Given this list of marker genes Mapkapk3, Kras, Grb2, Mapkapk2, Shc1, Sos1, Mapk11, Mapk14, Hras, Shc2, Ralgds, Shc3, here is a description of the gene set: Signalling to RAS studied in species Mus musculus Mouse Gene Set: REACTOME_SIGNALLING_TO_RAS